The following is a description of a gene set: The biosynthesis of dermatan sulfate/chondroitin sulfate and heparin/heparan sulfate glycosaminoglycans (GAGs) starts with the formation of a tetrasaccharide linker sequence to the core protein. The first step is the addition of xylose to the hydroxy group of specific serine residues on the core protein. Subsequent additions of two galactoses and a glucuronide moiety completes the linker sequence. From here, the next hexosamine addition is critical as it determines which GAG is formed (Lamberg & Stoolmiller 1974, Pavao et al. 2006). part of: Glycosaminoglycan metabolism Reactome Pathway: Glycosaminoglycan-protein linkage region biosynthesis studied in species Homo sapiens, and this is the list of marker genes: VCAN, BGN, GPC3, SDC2, CSPG4, B3GAT2 (NCBI Gene Id 27088), PXYLP1, GPC4, UXS1, SDC1, B3GAT1, FAM20B, GPC1, B3GAT3, B4GALT7, XYLT1, HSPG2, SDC3, CSPG5, NCAN, AGRN, BCAN, GPC6, GPC2, DCN, SDC4, XYLT2, B3GALT6, GPC5